Given this list of marker genes Fosb, Fos, Klf2, S100a10, Jun, Junb, Ubc (ubiquitin C), here is a description of the gene set: Cytokines mediate cell-cell communication in the immune system and represent important therapeutic targets. A myriad of studies have highlighted their central role in immune function, yet we lack a global view of the cellular responses of each immune cell type to each cytokine. To address this gap, the authors created the Immune Dictionary, a compendium of single-cell transcriptomic profiles of more than 17 immune cell types in response to each of 86 cytokines (>1,400 cytokine-cell type combinations) in mouse lymph nodes in vivo. A cytokine-centric view of the dictionary revealed that most cytokines induce highly cell-type-specific responses. For example, the inflammatory cytokine interleukin-1β induces distinct gene programmes in almost every cell type. A cell-type-centric view of the dictionary identified more than 66 cytokine-driven cellular polarization states across immune cell types, including previously uncharacterized states such as an interleukin-18-induced polyfunctional natural killer cell state. studied in species Mus musculus Mouse Gene Set: CUI_T_CELL_GD_IL17E_RESPONSE_DN Genes negatively differentially expressed in cell type: γδ T cell upon treatment with cytokine: IL-17E in mouse lymph nodes in vivo. from publication Cui A, Huang T, Li S, Ma A, Pérez JL, Sander C, Keskin DB, Wu CJ, Fraenkel E, Hacohen N (PMID 38057668)